Given this list of marker genes Hebp1, App, Fpr-rs4 (formyl peptide receptor, related sequence 4), Fpr1, Fpr-rs7, Fpr-rs6, Ccl6, Fpr2, Ccl9, Fpr-rs3, Anxa1, Fpr3 (formyl peptide receptor 3), here is a description of the gene set: Mouse Gene Set: REACTOME_FORMYL_PEPTIDE_RECEPTORS_BIND_FORMYL_PEPTIDES_AND_MANY_OTHER_LIGANDS studied in species Mus musculus Formyl peptide receptors bind formyl peptides and many other ligands